Given this list of marker genes MED4, MTSS1, PPTC7, ADAMTS5, RFX7, ZNF800 (NCBI Gene Id 168850), RNF19A, SLC38A2, KATNBL1, ANKRD42, TMEM177, FGF9, MOB1A, ROR1, FBXO45, ANO6, BACH1, IGFBP5, DLGAP1, YOD1, MFSD14A, KBTBD2, SLC2A1, TGFBR1, ERC2, NFE2L2, SRCAP, C11orf52, C1R, IPO7, KAT2B, DLST, EGR2, SEPTIN2 (NCBI Gene Id 4735), KLF6, BICC1, VCPIP1, SBNO1, MMD (monocyte to macrophage differentiation associated), VEGFA, BMP2, WDFY3, MROH9, FBN1, ARHGAP19, RNF170, JAG1, NPR3, DPP10, WNK2, NLK, TSSK2, HDGFL3, EPB41L2, BEND4, TMEM260, NPL (NCBI Gene Id 80896), TANC2, ANKFY1, GPR161, STRADB, NDUFA12 (NADH:ubiquinone oxidoreductase subunit A12), DOK4, KLF9, TSPAN12, GALNT16, VEZF1, HDAC7, SNX2, EEIG1, CAPN1, WASF1, CEP350, DDHD2, TSC22D2, PRDM1, ELAVL2, MED13, RPUSD2, RNF32, LHFPL2, LRP4, UBR5, ATOSA, NUCKS1, TBC1D12, ABHD5, PRLR, here is a description of the gene set: Genes predicted to be targets of miRBase v22 microRNA hsa-miR-140-5p in miRDB v6.0 with MirTarget v4 prediction scores > 80 (high confidence targets). Human Gene Set: MIR140_5P species: Homo sapiens from publication Chen Y, Wang X (PMID 31504780)